The following is a description of a gene set: Human Gene Set: DESCARTES_FETAL_EYE_RETINAL_PIGMENT_CELLS species: Homo sapiens The gene expression program underlying the specification of human cell types is of fundamental interest. The study authors generated human cell atlases of gene expression and chromatin accessibility in fetal tissues. For gene expression, the study authors applied three-level combinatorial indexing to >110 samples representing 15 organs, ultimately profiling ~4 million single cells. The study authors leveraged the literature and other atlases to identify and annotate hundreds of cell types and subtypes, both within and across tissues. Our analyses focused on organ-specific specializations of broadly distributed cell types (such as blood, endothelial, and epithelial), sites of fetal erythropoiesis (which notably included the adrenal gland), and integration with mouse developmental atlases (such as conserved specification of blood cells). These data represent a rich resource for the exploration of in vivo human gene expression in diverse tissues and cell types. from publication Cao J, O'Day DR, Pliner HA, Kingsley PD, Deng M, Daza RM, Zager MA, Aldinger KA, Blecher-Gonen R, Zhang F, Spielmann M, Palis J, Doherty D, Steemers FJ, Glass IA, Trapnell C, Shendure J (PMID 33184181) Marker genes curated from the annotated cluster as represented in the Descartes Human Gene Expression During Development database., and this is the list of marker genes: PGR, ENSG00000231204, CCDC33, PRODH, LINC00670, GEM, ERMN, ITGAV, OR51E2, INPP5K, TRPC4, ENPP2, FYB2, TLCD4, PAFAH1B2P2, LINC00355 (long intergenic non-protein coding RNA 355), PRDM16, HORMAD2, ADTRP, ACOT11, LINC00645, PRKCQ, CRISPLD1, PLD5, ELOVL7, ENSG00000253778, SLC6A12, ATP6V1C2, SMG1P6, SLC39A12, RGR, BEST1, MFRP, ENSG00000255746, PRDM16-DT, SFRP5, SLC6A13, CNDP1, LMNTD1, COL8A1, SLC45A2, RPE65, PRKCQ-AS1, RLBP1, SLC22A8, PLGLA, CNBD1, MYOCD, MYRF, FAM83B, TTR, PCAT1, VAT1L, NPFFR1, PFKFB2, VEPH1, LINC00276, CCBE1, TMEM98, BMP6, MROH7, LRAT, RASSF6, LIN28B-AS1, PTGDS, SLC16A8, SLC26A7, ADRA2C (NCBI Gene Id 152), FRZB, BCO1, KCNQ4, CLDN19, LINC01239, ADAD2, SLC6A20, STRIP2, TMEM72 (transmembrane protein 72), TMEM235, DCDC2, SLC38A11